The following is a description of a gene set: studied in species Homo sapiens Human Gene Set: HP_ABNORMAL_TRAGUS_MORPHOLOGY Abnormal tragus morphology An abnormality of the tragus., and this is the list of marker genes: NUP188, FBXO11, KAT6A, DACT1, RNU4ATAC (RNA, U4atac small nuclear), GLI2, EFTUD2, KCTD1, SMCHD1, SF3B2, SALL1, RAP1B, PIGN